The following is a description of a gene set: Mouse Gene Set: MIR_93_5P from publication Chen Y, Wang X (PMID 31504780) Genes predicted to be targets of miRBase v22 microRNA mmu_miR_93_5p in miRDB v6.0 with MirTarget v4 prediction scores > 80 (high confidence targets). studied in species Mus musculus, and this is the list of marker genes: Trpv6, Agfg2, Abca1, Npas2 (neuronal PAS domain protein 2), Spred1, Septin2, Coro2b, 6430548M08Rik, Arhgef11, Plekha3, Wdfy3, Irf2bp2, Smoc2, Skor1 (SKI family transcriptional corepressor 1), Dennd5b, Rest, Rab30, Mospd2, Cnot7, Tasor, Zfyve26, Hs3st5, Cbln4, Tbc1d9, Akt3, Pcdha1, Ccng2, Bnc2, Zfp827, Abcg4, Gpr137c, Ppp1r21, Arid4b, Tph1, Tsg101, Zc3h12c, Crybg3, C2cd2, Arhgef18, Foxj3, Cmpk1, Fnbp1l, Arhgap1, Vash2, Pfkp, Slc25a40, Iqsec2, Elk3, Smim5, Lypd6, Col4a3, Brms1l, Pls1, Snx16, Rasgrf2, Aak1, Epha4, Atg16l1, Olfm1, Ube2q2, Frmd6, Clip4, Ahnak, Tfb2m, Bahd1, Mfn2, Nagk, Egln3, Csnk1g1, Spopl, Sh3bp2, Gon4l, Mosmo, Slc40a1, Naa30, Stx6, Dnajc24, Mmp24, Ddhd2, Rsrp1, St3gal1, Tle4, Mtmr3, Fzd3, Creb5, Mink1, Cd69, Rab22a, Camk2n2, Pcdha6, Tmcc3, Wdr37, Rundc1, Cc2d1a, Atg14, Zbtb9, Rps6ka1, Map6d1, Mex3d, B3galt2, Kcnb1, Arhgap26, Pcdha7, Nanos1, Uevld (UEV and lactate/malate dehyrogenase domains), Ormdl3, Ezh1, Flt1, Fsd1l, Creb1, Phip, Aktip, Pcdha3, Map3k2, Kcnq2, Zfp9, Luzp1, Napepld, Rcan3, Scn1a (sodium channel, voltage-gated, type I, alpha), Zbtb4, Rp2, Pkd1, Unkl, Ythdf3 (YTH N6-methyladenosine RNA binding protein 3), Unc80, Crot, Epha7, Pgbd5, Sema7a, Gab1, Hook3, Zdhhc1, Afg1l, Osm, Lrch1 (NCBI Gene Id 380916), Eif4a2 (NCBI Gene Id 13682), Sash1, Gabbr2, Chd9, Smad5, Pcdha4, Kpna2, Ssh2, Gosr1, Topors, Dennd10, Crk, Bmpr2, Lima1, Map3k14, Rbl2, Gpr63, Tbc1d12, Slc31a2, Atad2, Nr2c2, Reep3, Armc8, Arhgap35, Tmed8, Cfl2, Trappc14, Gid4, Csrnp3, Bnip2, Cdca7, Vangl1, Timp2, Smyd1, Rab5b, Cast, Laptm4a, Derl2, Mapre3, Stxbp5, Pcdha5, Susd6, Slc17a8, Clock, Mylip, Kif3b, Ankrd17, Ism2, Fam219b (family with sequence similarity 219, member B), U2surp, Rasd1, Rb1cc1, Ankib1, Ccdc71l, Rnf2, St8sia2, St6galnac6, Pcdhac1, Kcnk10, Irf9, Lrrc55, Dsg4, Pkd2l2, Itpripl2, Pxk, Mfap3l, Idua, Tet1, Rab10, Bicd2, Tnfaip1, Slc17a7, Cep97, Dmtf1, Ginm1, Ptpn4, Tnks1bp1, Pcdha10, Rgs17, Sall1, Zbtb18, Kdm2a, Xrn1, Purb, Tbcel, Znfx1 (NCBI Gene Id 98999), Chrm2, Rsbn1, Psd, Heg1, Zfp800, Ptpn21, Atl3, Mkrn1, Myt1l, Arhgef10, S1pr1, Map3k8, Ankrd9, Hlf, Trappc2, Lhx6, Nrip3 (NCBI Gene Id 78593), Cnot6l, E2f1, Fastk, Ppp1r15b, Ano3, Fam13c, Sar1b, Pcdhac2, Zfp148 (zinc finger protein 148), Rab8b, Ints14, Zhx2 (zinc fingers and homeoboxes 2), Zfand4, Rb1, Pde3b, Dab2, Dpysl2, Ntng1, Jpt1, Plxdc2, Ptpn3, Lrp8, Ankrd52, Nckap5, Lama3 (laminin, alpha 3), Btg3, Ldlrap1 (NCBI Gene Id 230816), Snx8, Marchf8, Uri1, Fbxl5, Fat2, Plekha7, Tiam1, Frs2, Midn, Hbp1, Ube3c, Ptchd4, Trip11, Arhgap12, Slc12a7, Kif23, Zfp91, Il25, Pcdha8, Fgd5, Glis3, Nfat5, Rassf2, Ddhd1, Rps6ka4 (ribosomal protein S6 kinase, polypeptide 4), Ulk1, App, Rap2c, Pcdha11, Pbx3, Gpc6, Rnf6, Acer2, Pcsk5, Unk, Med12l, Reps2, Itgb8, Atxn1l, Zfp704, Zfpm2, Tmem267, Dpysl5, Tars2, Ogfod2, Oxr1 (NCBI Gene Id 74830), Kmt2b, Sobp, Gxylt1, Wfs1, Rnf128, Rab11fip5, Rs1, Ano5, Map3k12, Myf5, Klf11, Slc16a9, Rbbp7, Ndel1, Nabp1, Suco, Fat4, Tspan9, Kmt2a, Mier1, Sertad2, Ppp1r3b, Ago1, Fcho2, Zdhhc8, Mastl, Map3k13, Nup35, Fjx1, Rhoc, Slc24a2, M6pr, Pcdha9, Hycc2, Tanc2, Rufy2, Gpr137b, Rasl11b, Pgm2l1, Sqstm1, Gramd1a, Pdcd1lg2, Pcdha2, Pkn2, Pthlh, Prrg1, Pitpna, Mcl1 (NCBI Gene Id 99928), Pcdha12, Pak5, Enpp5, Fibin, Srpk2, Has2, Smoc1, Tbc1d8b, Txnip, Tgfbr2, Tmem127, Nek9, Cep57, Polr3g, Kat2b, Map7 (NCBI Gene Id 97677), Zfp367, Sorl1, Panx2, Bbx, 2510009E07Rik, Slc18a2, Limk1, Sema4b, Zfp512b, Nbea, Dock4, Slc2a4, Nedd4l, Usp3, Slc49a4, Lpgat1, Chmp4c, Trip10, Eri1, Pkd2, Npat, Pafah1b1, Rapgefl1, Srgap1, Usp24, Tafa1, Zfp661, Usp32, Dcbld2, E2f5, Tnks2, Tnfrsf21, Pdgfra, Sfmbt1 (NCBI Gene Id 78161), Mapk4, Ppp1r3e, Cep120, Usp46, Apcdd1, Prr14l, Prr15, Retreg3, Rnf150, Sos1, Sybu, Ankrd13c, Bcl11b, Pex5l, Mknk2, Jazf1, Dusp2, Retreg2, Atxn7l1, Ahrr, Rgmb, Rgma, Srcin1, Dnal1, Zfp236, Ncoa3, Prepl, Osr1, Rab33b, St6galnac3, Ankrd33b, Fbxo28, Fyco1, Klhl28, Sumf1, Klf9, Camta2, Btbd10, Akap13, F3, Sall3, Fgd4, Kif5a, Sh3pxd2a, Col4a4, Adam9, Neurog3, Acsl4, 1600012H06Rik, Zbtb41, Rps6ka5, Trim3, Slc22a23, Slc16a6, Tmem64, Trim36, Ugdh